The following is a description of a gene set: An intracellular signaling cascade that starts with the activation of hippo (STK4/MST1 and STK3/MST2 in mammals and hpo kinase in Drosophila). Hippo then phosphorylates LATS1/2, which in turn phosphoylates the transcriptional co-activator YAP1 (yki in Drosophila), leading to its cytosolic retention and/or degradation. species: Mus musculus Mouse Gene Set: GOBP_HIPPO_SIGNALING, and this is the list of marker genes: Iqschfp, Lats2, Stk4, Vcp, Wwc2, Nuak2, Wwc1, Wtip, Sox11, Wwtr1, Cit, Tead3, Dlg5, Slmap, Strn3, Tead2, Aars1, Dchs1, Lats1, Mark3, Stk3, Coro7, Ywhae, Mob1a, Tial1, Src, Tead4, Sirt1, Strip1, Ppp2r1a, Tead1, Frmd6, Nek8, Vgll4, Limd1, Sike1, Shank2, Prpf4b, Yap1, Strn4, Amotl2, Arrdc3, Fat4, Mapk14, Amotl1, Nf2, Ppp2ca, Amot, Sav1, Mob1b, Map2k3, Map4k4, Mob4, Mob3b, Schip1, Ajuba